The following is a description of a gene set: from publication Chen Y, Wang X (PMID 31504780) studied in species Mus musculus Genes predicted to be targets of miRBase v22 microRNA mmu_miR_7035_5p in miRDB v6.0 with MirTarget v4 prediction scores > 80 (high confidence targets). Mouse Gene Set: MIR_7035_5P, and this is the list of marker genes: Clca3a1, Slc5a12, Cfap300 (NCBI Gene Id 234912), Abr, Rgs13, Ska3, Dqx1, Lss, Timd5, Myl9, Zfp622, Cd96, Nom1, Apold1, Fbxo41, Mboat7, Dnajb6, 2310022B05Rik, Dido1, Parpbp, Pip4k2a, Adarb1, Mfsd4b5, Znrf1, Mfsd2b, Bmal2, Mllt6, Chst3, Kcns2, Nxph1, Ceacam20, Asprv1, Pir, Fbxo17, Eeig1, Mob3a, Mau2, Zkscan1, Ccr9, Cdh4, 1700123K08Rik, Lyrm9, Zfp59, Smarcd1, Utp6, Soat2, Ctnnbl1 (catenin, beta like 1), Erbb4, Spaca7b, Rhov (NCBI Gene Id 228543), Gpr4, Slfn5, Erich1, Ippk, Sp5, N6amt1, Snapc5, Lpl, Mocs2, Rnaseh2a, Dph5, Tomt, Zyg11b, Acsf2, Rspo1 (NCBI Gene Id 192199), Tspan15, Crtc3, Nfic, Wdr31, Acmsd, Tlx1, Lad1, Mrpl10, Ccser2, Mpp2, Rabggta, Rnf168, Prf1, Dcaf17, Homer1, Rab11fip1, Tbc1d22b, Slc11a1, Strip1, Mrpl51, Zfp949, Aak1, Dnd1, Fam227a, Cnr2, Plagl1 (NCBI Gene Id 70469), Ube2z, Trpc5, Cgas, Klhl7, Adgrf1, Lin7a, Sh3d19, Prkd2, Zfp12, Taf1, Mtfmt, Arl16, Trappc5, Pcsk1n, Stxbp5 (syntaxin binding protein 5 (tomosyn)), Usf2 (NCBI Gene Id 22282), Dele1, Cyp2c40, Il17rd, Pogz, Lifr, Cpsf2, Zfp316, Rft1, Dlg2, Heatr6, Mre11a, Urb2, Moap1, Pip5k1c, Ralgps1, C1rl, Sec22a, Crx, Ldah, Dync2i2 (NCBI Gene Id 71820), Etf1, Mprip, Ogdh, Cel, Kirrel3, Hs6st2, Hdhd2, Pla2g5, Vapb, Rasl10b, Cd151, Txndc17, Nlrp12, Ano6, Tns4, Rbm8a, Prorsd1, Cacna1e, Birc5, Mrpl45, 2610028H24Rik, Arsg, Ncl, Elavl1, Dpysl3, Tacc1, Mpv17, Malt1, Pdzd2, Hpgds, Wnt7a, Psma3, Hip1, Timm8a2, Nos1, Rbbp4, Rnf145, Ifngr2, Slc7a8, Glod4, Pbx1, Slc6a17, Acat1, Tmx2, Myo1c, Zfp935, Mindy4, Fgf1, Fbxw2, Csf2rb, Ceacam2, Zbtb8b, Pacs1, Tbc1d24, Lima1, Slc9a4, Med1, Gab2, Chek2, Capn6, Etfrf1, Hk1, Ccdc157, Nup133, Trp53rka, Npcd, Dnajb5, Mtif2, Tmppe, Gabpb2, Yeats2, Ankle1, Neo1, Churc1, Nvl, Trim72, Rwdd2b, Odad4, Slc17a5, Vti1a (NCBI Gene Id 70938), Psmd9, Naxd, Oprd1, Nectin1, Reep6, Rassf6, Ceacam1, Castor2 (cytosolic arginine sensor for mTORC1 subunit 2), Mrpl9 (mitochondrial ribosomal protein L9), Stxbp5l, Spn, Zfp408, Galm, Cd4, Cyp2e1, Vps26b, Tbc1d5, Padi1, Tmem19, Fzd3, Slc1a4, S1pr5, Fblim1, Nphs1, Raph1, Epb41l1, Deptor, Aifm3, Sass6, Eef2k, Uvssa (UV stimulated scaffold protein A), Ago1, Camk2d, Slc22a15, Gcsh, Epha2, Doc2b, Egln3, Rreb1, Il22ra2, Eif1ad19, Als2cl, Haus2, Klk11, Nif3l1, Sun2, Lrrc2, Scrt1, Endov, Tmem104, Gpatch8, Alox8, Tbc1d9b, Stard8, Septin5, Gm12253, Ankfy1, Sema4c, Zfp609, Mfsd11, Trp53rkb, Gtf2h3, Sorbs3, Oog2, Pax7, Cyb561a3, Igf2bp1, Zfp612, Trip4, Emc4, Prlhr, Coq4, Nptxr, Zdhhc20, Kank2, Rabgap1l (NCBI Gene Id 98656), Uba1, Foxr1, Siae, Borcs7, Cln6, Rpl37, Rgp1, Dph7, L3mbtl2, Ptgs1, Limk2, Adsl, Atp2b2, Serf2, Sppl2b, Ifnar1 (NCBI Gene Id 15975), Prkn (parkin RBR E3 ubiquitin protein ligase), Arhgap44, Ophn1, H2-T23, Mgat4a, Fam83a, Qng1, Cnga3, Bco2, Nav1 (NCBI Gene Id 408054), Ushbp1, Nmnat2, Aoc3, Slc43a2, Riok3, Cyp2c67, Nlrp1a, Slc35a4, Pex10, Bmpr2, Tns1 (tensin 1)